The following is a description of a gene set: Reactome Pathway: SUMOylation electronically inferred by orthology from the curated human pathway This event has been computationally inferred from an event that has been demonstrated in another species.<p>The inference is based on the homology mapping from PANTHER. Briefly, reactions for which all involved PhysicalEntities (in input, output and catalyst) have a mapped orthologue/paralogue (for complexes at least 75% of components must have a mapping) are inferred to the other species. species: Mus musculus part of: Post-translational protein modification, and this is the list of marker genes: Nup205, Nup210, Vhl, H4c2, Nup58, Top2a, Smc6 (NCBI Gene Id 67241), Nup85, Nup155, Nup54 (nucleoporin 54), Brca1, Scmh1, Aurkb, Ndc1, Nr1i2, Sumo1, Rpa1, Ring1, Cbx2, H4c6, Nup42, Nr3c1, Daxx, Aaas, Nfkbia, H4c1, Zfp131, H4c4, H4c9, Nup93, Nsmce2 (NCBI Gene Id 68501), Rnf168, Mitf, Foxl2 (forkhead box L2), Senp2 (SUMO/sentrin specific peptidase 2), Nsmce4a, Rad21 (RAD21 cohesin complex component), Phc1, Ar, Stag1, H4c3, Nsmce3, Ep300, Rara, Bmi1, Pias4, Sin3a (NCBI Gene Id 20466), Nop58, H4c18, Trim27, Cbx8, Mbd1, H4c8, Mta1, Hdac7, Nup133, Vdr, Dnmt3b, Eid3, Nfkb2, Hic1, Smc3, Mrtfa, Esr1, Seh1l, Blm, H4c11, H4c14, Tdg, Ing2, H4c12, Dnmt1, Thrb, Hdac4 (histone deacetylase 4), Rwdd2b, Rae1, Satb2, Xpc, Pcgf2, Nr5a1, Mdc1, Ncoa1, Cbx4, Rela, Rad52, Park7, H4c17, Nsmce1, Trp53bp1, Npm1, Pcna, L3mbtl2, Nr1h4, Hnrnpk